Given this list of marker genes TPP1, CCND3, COX7B, AKR1B1, DNAJC25, CCNE2, RUBCNL, VPS26C, B3GNT7, ARSB, ARHGAP26, PPIB, MAP1LC3B, HASPIN, KNSTRN, MRPL13, E2F7, MDFIC, LGALS1, CCNA2, IFNGR1, UBE2C, ORMDL2, B4GALT1, FAS, NDUFS4, SVBP, SULF2 (NCBI Gene Id 55959), ANXA2P2, MRPL30, PAK1IP1, KRT25, SYNJ1, RBKS, TRAPPC13, OIP5, ATP5PO (NCBI Gene Id 539), MTMR14, UBE2T, CDCA2, RNASE6, APLN, FCER1G, KIF18B, TROAP, SH2B3, MS4A7, PBLD, PXK, DTL, SET, VPS29, SPCS1, MORN2 (NCBI Gene Id 732175), COX16, COMMD10, LY86, NMT1, ESPL1, UBE2E2, KPNA2, GRB2, FANCB (NCBI Gene Id 2187), ALKBH1, SIGLEC5, DTYMK, S100B, IQGAP3, JCHAIN, NXT2, FDX1, IL10RA, ASRGL1, FBXO5, RASSF5, H1-5, USP38, PCLAF, DDIAS, KIF23, SFT2D2, E2F8, KCTD6, MIS18A, ANXA2, ALOX5AP, BUB3, CKAP2L (NCBI Gene Id 150468), CENPE, CD38, ARL6IP1, NSD2, NIBAN3, CRIP1, GXYLT2, ERCC8, ATAD2B, MIS12, ITGB7, POLR1F, TMED7, HERPUD1 (homocysteine inducible ER protein with ubiquitin like domain 1), CBR3-AS1, TLR2, MYBL2, SEC11C, NDUFC2, NUP50, FGFR2, KIF14, CEP152, SHCBP1, CTNNAL1, PLA2G15, ARHGAP11A, MOB3B, UQCC3, MRPS33, ECT2, RPA3 (replication protein A3), SHLD1, BOLA3, ITGB2, MTMR1, PFDN4, WDR4, AP1S2, C12orf75, FHIP1A, CCNG2, DAD1, ANGPTL1, IL17RA, NEK2, ADAM19, ACTR2, POLR2G, FANCG, CKS2, CCNB2, LASP1, TOMM22, NTAN1, ANLN, FIBP, CDKN3, CYB5R4, PTPRS, LGMN, CKS1B, BASP1, NCAPH, PIK3R5, TXNDC12 (thioredoxin domain containing 12), TRAPPC1, P2RY2 (purinergic receptor P2Y2), TTK, STMN1, GNG5, HLA-DRA, SERF1A, MTHFD1, POLR2K, CALM1, HMGN2, MCTS1, COX17, MICB, SCP2, SSR3, TGFBI, NDUFA12, CENPS, ICMT, POLR2I, CIAPIN1, DSN1, POLA2, CAPSL, MFF, CENPC, SCPEP1, SPPL3, INSR, MAP3K1, F13A1, TBCC, KIF11, IGKC, CLSPN, RASSF2, TM9SF2, DNAJC15, TMEM14A, GGH, SLC39A12, RAB11FIP1, here is a description of the gene set: IL-10 regulates anti-inflammatory signaling via the activation of STAT3, which in turn controls the induction of a gene expression program whose products execute inhibitory effects on pro-inflammatory mediator production. Here we show that IL-10 induces the expression of an ETS family transcriptional repressor, ETV3 and a helicase family co-repressor, SBNO2 (Strawberry notch homolog 2) in mouse and human macrophages. IL-10-mediated induction of ETV3 and SBNO2 expression was dependent upon both STAT3, and co-stimulus through the TLR pathway. We also observed that ETV3 expression was strongly induced by the STAT3 pathway induced by IL-10 but not STAT3 signaling activated by IL-6, which cannot activate the anti-inflammatory signaling pathway. ETV3 and SBNO2 specifically repressed NF-kB-mediated transcription and can physically interact. Collectively our data suggest that ETV3 and SBNO2 are components of the pathways that contribute to the downstream anti-inflammatory effects of IL-10. We compared expression profiles of macrophages isolated from IL-10 -/- mice. Macrophages were treated with either LPS or LPS plus IL-10. Treatment times were 10, 20 and 30 minutes. species: Homo sapiens Human Gene Set: GSE9509_LPS_VS_LPS_AND_IL10_STIM_IL10_KO_MACROPHAGE_20MIN_DN Genes down-regulated in macrophages with IL10 knockout in response to 20 min treatment by: LPS versus LPS and IL10. from publication El Kasmi KC, Smith AM, Williams L, Neale G, Panopoulos AD, Watowich SS, Häcker H, Foxwell BM, Murray PJ (PMID 18025162)